Given this list of marker genes Ptpn11, Hgf (hepatocyte growth factor), Gab1, Grb2, Met, here is a description of the gene set: MET activates PTPN11 species: Mus musculus Mouse Gene Set: REACTOME_MET_ACTIVATES_PTPN11